The following is a description of a gene set: Catalysis of the reaction: an alcohol + NAD+ = an aldehyde or ketone + NADH + H+. Mouse Gene Set: GOMF_ALCOHOL_DEHYDROGENASE_NADPLUS_ACTIVITY studied in species Mus musculus, and this is the list of marker genes: Rdh7, Rdh5, Adh4, Dhrs3, Akr1cl, Hsd17b13, Rdh16, Akr1c18, Sdr9c7, Rdh19, Adh5, Sord, Rdh1, Rdh12 (NCBI Gene Id 77974), Hsd17b6, Rdh11, Rdh8, Akr1a1, Rdh16f2, Rdh10, Akr1c20, Dhrs7c, Dhrs9, Akr1c6, Adh6b, Adh7, Sdr16c5, Akr1c14 (aldo-keto reductase family 1, member C14), Adhfe1, Adh6a, Rdh9 (retinol dehydrogenase 9), Adh1